Given this list of marker genes UROS (NCBI Gene Id 7390), ETS1, IRAK1, DOCK11, NRAS, SLC19A1 (solute carrier family 19 member 1), PI4KA, LCAT, CTLA4, HELLPAR, IGHG1, TNIP1, TNFRSF13B, HBA1, ARPC5, KLF1, ABCG5, CD59, ZAP70 (zeta chain of T cell receptor associated protein kinase 70), PFKM, FCGR2B, PRKCD, FOXN1, CD81, PIGT, CD247, SAT1, ACP5, ADA, CDAN1, NT5C3A, KIAA0319L, GYPC, FOXP3, LAT, ALDOA, CD46, DEF6, DRG1, SOCS1, DGKE, PXK, COL4A1, BCL11A, C4B, IFIH1, KCNN4, KRAS, CFB, GNB2, CIITA, ABCB6, MS4A1, CR2, FCGR2A, ICOS, TLR7, FCGR3B, PDCD1, G6PD, DNASE1, C4A, LRBA, RAG1, GSS, STAT3, SLC4A1, TRAC, BTNL2, CYBC1, PKLR, LCP2, CBLB, HBG1, GALT, PIEZO1, HBG2 (hemoglobin subunit gamma 2), CFI, PGK1, HK1, HGD, PSMG2, TLR8, RFXAP, TTC7A (NCBI Gene Id 57217), RFXANK, PNP, ITGAM, RHAG, GPX1, RAG2, IL2RB (NCBI Gene Id 3602), JAZF1 (JAZF zinc finger 1), HBA2, ALAD, STIM1, CD40LG, TREX1, BANK1, WAS, GP1BA, TPP2, ANK1, NLRP1, TNFAIP3, IL10, GSR, TNFRSF4, C3, PTPN22, EPB42, HLA-DRB1, THBD, CPOX, NHLRC2, SLC2A1, PIGA (NCBI Gene Id 5277), WIPF1, IRF5, IL2RA, RHCE, HBB, EPB41 (NCBI Gene Id 2035), STK4, ATP7B, MECP2, CD3G, ABCG8, TNFSF4, UROD, CFH, IRF2BP2, FASLG, ATP11C, CFHR1, KMT2D, KDM6A, STAT1, GATA1, GPI, SPTA1, BLK, STAT4, GCLC, C1GALT1C1, NBN, SPP1, NFKB1, RNU7-1, CASP10, RASGRP1, PIK3CG, NFKB2, ADAMTS13, FAS, RHD, TPI1, UBE2L3, CD19, TNFSF12, AK1, CFHR3, PGM3, ADAR, HMOX1, TNFRSF13C, SPTB, ITK (IL2 inducible T cell kinase), RFX5, FECH, CASK, here is a description of the gene set: Human Gene Set: HP_ANEMIA_DUE_TO_REDUCED_LIFE_SPAN_OF_RED_CELLS A type of anemia related to a reduction in the average life span of red blood cells in the peripheral circulation, which is normally around 120 days. Anemia due to reduced life span of red cells species: Homo sapiens